Given this list of marker genes RCC2, ARFGEF1, RDX, GPSM1, PLXNB3, ARL2, FICD, KLRK1, DAB2IP, SH3BP4, LRCH1, RRP1B, USP17L2, LRRK2, KLRC4-KLRK1, RASA4, TMED2, here is a description of the gene set: studied in species Homo sapiens Human Gene Set: GOBP_NEGATIVE_REGULATION_OF_GTPASE_ACTIVITY Any process that stops or reduces the rate of GTP hydrolysis by a GTPase.